The following is a description of a gene set: Genes up-regulated in CXCR5- BCL6- CD4+ T cells versus CXCR5+ BCL6- follicular helper T cells. studied in species Homo sapiens T follicular helper (Tfh) cells play a pivotal role in germinal center reactions, which requires Bcl6 transcription factor. To analyze their relationships with other effector T cell lineages and their stability in vivo, we developed and analyzed a new Bcl6 reporter mouse alone or together with other lineage reporter systems. Assisted with genome-wide transcriptome analysis, we show substantial plasticity of T cell differentiation in the early phase of immune response. At this stage, CXCR5 appears to be expressed in a Bcl6-independent manner. Once Bcl6 is highly expressed, Tfh cells can persist in vivo and some of them develop into memory cells. Together, our results indicate Bcl6 as a bona fide marker for Tfh polarized program. from publication Liu X, Yan X, Zhong B, Nurieva RI, Wang A, Wang X, Martin-Orozco N, Wang Y, Chang SH, Esplugues E, Flavell RA, Tian Q, Dong C (PMID 22987803) Human Gene Set: GSE40068_CXCR5NEG_BCL6NEG_CD4_TCELL_VS_CXCR5POS_BCL6NEG_TFH_UP, and this is the list of marker genes: ARHGAP21, CLCN5, CTSW, PLXDC1, MMD, PIH1D1, SAP30 (NCBI Gene Id 8819), TFG, GEMIN2, ARPC4, C4orf46 (NCBI Gene Id 201725), NGLY1, NT5E, HSD11B1, NFATC2, SEC61B, GNA15, ERRFI1 (ERBB receptor feedback inhibitor 1), NAAA, CMSS1, NUP37, ATP2A2, LYZL6, RAD51C, REEP4, UPB1, SPC24 (NCBI Gene Id 147841), VPS26C, SSR1, AMMECR1, ROPN1L, YAP1, NUDT22, NUTF2, MGME1, GINS2, FRMD4B, B4GALT5, RGS1, MELK, DHRS1, LANCL2, TXNDC17, GFPT1, NXN, KIF20A, GDAP2, FCER1G, POGK, NCBP2, RNASEH2B, CAPN2, OSBPL9, NAA15, SFTPB, ZCCHC3, TTF2, VAX2, RDM1, SMPDL3B (NCBI Gene Id 27293), WDHD1, NUP62, NIF3L1, AP1S2, TUBE1, RHBDF2, CDK5R2, FAAP24, LHX2 (NCBI Gene Id 9355), ACSBG1, RAB5IF, MVB12A, NDUFB9, TRMT1L, OIP5, OPTN, SGCB, CCNC, CASP7, TAMM41, ERN1, GRN, HINT1, PPP2R1B, NUS1, GTSE1, HSPA1B, FANCF, BCAT1, PAK6, DNA2, ATP1A2, CRYBG3, RAB8A, EFHD2, CYP11A1 (cytochrome P450 family 11 subfamily A member 1), DNASE1L3, CARNMT1, CAMK2N2, DNAJC15, CENPV, TMEM140 (transmembrane protein 140), SLIRP, BSG, UQCRQ, PRIM2, ALAS1, ITGB1, MXD3, DOK2, GMDS, LGALS3BP, S100A5, UGP2, SUV39H1, PCSK7, PCDHGC4, NEIL3, CDK1, CSF1, PPIA, OSTF1, MAFG, NDUFAF7, PICALM, TUBB3, TXNDC9, TPST2, CTLA4, TSPAN3, ARHGAP19, AP2M1, CKAP5, MLKL, CCDC141, IL2RA (interleukin 2 receptor subunit alpha), GZMK, SCPEP1, PDIK1L, ZNF654, MAP2K4, ATOSB, SYCE2, GIMAP7, HELQ, SPATS2, LMAN2, IRAK1BP1, CHCT1, FBXO44, HROB, UQCR10, RBX1, NFIL3, SLC2A8, LACTB, GTF2E2, SERHL2, SERPINB9, FAM177A1, BORA, NEK7, PTPN12, CERCAM, MYL4, CAPZB, PPP3CC, NUP93, HPF1, RFC3, ANXA4, ADAM8, MYD88, RHOC, ICA1, CCR2, TSHB, IRAK3, PEAR1, GLMP, CD109, GALNT3, TOPBP1, CRAMP1, MYEF2, MACROH2A2, ZFPM1 (zinc finger protein, FOG family member 1), TG, MMS22L, STK35, HIP1R, AUNIP, SAPCD2, G6PD, ZFAND4, CENPS, CD80, ADPRH, CARHSP1, PKIG